The following is a description of a gene set: A component of the transcription machinery of RNA Polymerase II. In humans, TFIIA is a heterotrimer composed of an alpha (P35), beta (P19) and gamma subunits (P12). Human Gene Set: GOCC_TRANSCRIPTION_FACTOR_TFIIA_COMPLEX studied in species Homo sapiens, and this is the list of marker genes: TBPL1, TBP, GTF2A1L, GTF2A2, GTF2A1